Given this list of marker genes DTNBP1, GPER1, SYT1, BGLAP, STX1B, PPP3CA, CACNA1B, RAB3GAP1, STXBP1, MICU3, BAIAP3, SLC18A3, SLC4A8, GPR158, STX1A, ADORA2A, TACR2, NLGN1, SNCA, KMO, here is a description of the gene set: studied in species Homo sapiens Human Gene Set: GOBP_POSITIVE_REGULATION_OF_NEUROTRANSMITTER_SECRETION Any process that activates or increases the frequency, rate or extent of the regulated release of a neurotransmitter.